The following is a description of a gene set: Any deviation from the normal amount of a purine compound in the urine. Purines are aromatic heterocyclic compounds containing a purine moiety, which is formed a pyrimidine-ring ring fused to an imidazole ring. Two of the four deoxyribonucleotides (deoxyadenosine and deoxyguanosine) and two of the four ribonucleotides (adenosine, or AMP, and guanosine, or GMP) are purines. species: Homo sapiens Human Gene Set: HP_ABNORMAL_URINARY_PURINE_LEVEL Abnormal urinary purine level, and this is the list of marker genes: ADSL, MOCS2, CHUK, MOCS1, MOCOS, APRT, PNP, ATIC